Given this list of marker genes VSTM2L, UBE2B, HOXA9, CCDC88A, ATAD2, COL4A5, HSP90AB1, FBXO36, GIPC1, UBE2D3, TCF12, POGZ, GSK3B, DNAI4, MBD6, GPRASP1, NOTCH1, CFAP20, CYP51A1, UBC, MIER1, GNB2, ATF4, KDM3A, IL4I1, MAML3, FOXJ3, AP1G1, CALM1, COL4A6, HIVEP3, USPL1, CLTC, RBL1, GPRASP2, SRSF7, HTN1, STK35, ATF5, HOXD8, CCNG2, NUP62, SNRNP70, TSC1, PPP1CC, UBE2D2, GABPB2, KDM5A (NCBI Gene Id 5927), CALM2, WBP2, PAX6, HEXIM2, KDM5C, here is a description of the gene set: Genes having at least one occurrence of the highly conserved motif M99 ATCMNTCCGY in the regions spanning 4 kb centered on their transcription starting sites. The motif does not match any known transcription factor binding site. studied in species Homo sapiens Human Gene Set: ATCMNTCCGY_UNKNOWN Comprehensive identification of all functional elements encoded in the human genome is a fundamental need in biomedical research. Here, we present a comparative analysis of the human, mouse, rat and dog genomes to create a systematic catalogue of common regulatory motifs in promoters and 3' untranslated regions (3' UTRs). The promoter analysis yields 174 candidate motifs, including most previously known transcription-factor binding sites and 105 new motifs. The 3'-UTR analysis yields 106 motifs likely to be involved in post-transcriptional regulation. Nearly one-half are associated with microRNAs (miRNAs), leading to the discovery of many new miRNA genes and their likely target genes. Our results suggest that previous estimates of the number of human miRNA genes were low, and that miRNAs regulate at least 20% of human genes. The overall results provide a systematic view of gene regulation in the human, which will be refined as additional mammalian genomes become available. from publication Xie X, Lu J, Kulbokas EJ, Golub TR, Mootha V, Lindblad-Toh K, Lander ES, Kellis M (PMID 15735639)